The following is a description of a gene set: Reactome Pathway: Scavenging of heme from plasma Free heme is damaging to tissues as it intercalates into biologic membranes, perturbing lipid bilayers and promoting the conversion of low-density lipoprotein to cytotoxic oxidized products. Moreover, it represents a source of redox-active iron that, participating in the Fenton reaction, generates oxygen radicals. Free heme in plasma is mainly generated from hemoglobin released by circulating erythrocytes in pathologic conditions associated with intravascular hemolysis. Free hemoglobin in plasma is scavenged by the extracellular protein haptoglobin. Haptoglobin is produced by the liver and secreted into the plasma. Haptoglobin binds dimers of hemoglobin subunits rather than the intact tetramer. The resulting haptoglobin:hemoglobin complex is then bound by CD163, expressed on plasma membranes of monocytes and macrophages, and endocytosed. When the buffering capacity of plasma haptoglobin is overwhelmed, heme is released from methemoglobin and it is bound by albumin and then transferred to hemopexin. Hemopexin is produced mainly in the liver. Once secreted into the plasma, hemopexin binds heme and the hemopexin:heme complex is then preferentially delivered to liver hepatocytes, bound by LRP1 (CD91) and endocytosed. part of: Binding and Uptake of Ligands by Scavenger Receptors species: Homo sapiens, and this is the list of marker genes: APOA1, IGHV1-46, IGHV4-34, ALB, IGLV6-57, IGLC1, IGKV1-33, IGHV3-30, IGLC6 (immunoglobulin lambda constant 6), HPR, IGKV4-1, IGHV3-53, IGKV1D-12, IGKV3-15, IGLV3-27, IGKV1D-33 (NCBI Gene Id 652694), IGLV2-18, IGKV1-39, IGLV4-60, IGKV2-29, IGHV1-2, IGLV4-3, IGLV4-69, CD163, IGHV3-7, IGLV8-61, IGLV2-8, IGLV10-54, IGHV3-11 (immunoglobulin heavy variable 3-11), IGHV3-13, IGKV5-2, IGHV2-5, HBA1, IGLV5-37, IGHV, IGLV3-25, IGKV2D-30, IGKV2-28, IGKV3-11, IGLV3-1, IGKC, IGLV3-22, IGHV3-33, IGHV4-39, IGKV1-17, IGHV3-48, IGHA2, HBB, IGLV2-23, IGLV5-45, IGLV3-21, IGLV3-12, IGLV7-46, APOL1, IGLV2-11, IGLV, IGHV7-81, IGHV3-23, IGKV1D-16, IGHA1, IGKV1-12, IGKV1D-39, HPX, IGLC3, IGLV2-14, IGLV1-51, LRP1, HP, IGHV1-69, IGKV1-5, IGHV4-59, IGLV2-33, IGKV2D-28, IGKV3D-20, IGLV1-40, IGLV7-43, IGKV1-16, JCHAIN, IGLV3-16, IGKV2-30 (NCBI Gene Id 28919), IGLV1-47, IGLC7, IGLV1-36 (NCBI Gene Id 28826), IGKV2D-40, IGHV2-70, IGKV3-20, AMBP, IGLC2, IGLV11-55, IGHV3-9, IGLV3-19, IGLV1-44